The following is a description of a gene set: studied in species Mus musculus Genes predicted to be targets of miRBase v22 microRNA mmu_miR_497b in miRDB v6.0 with MirTarget v4 prediction scores > 80 (high confidence targets). Mouse Gene Set: MIR_497B from publication Chen Y, Wang X (PMID 31504780), and this is the list of marker genes: Sobp, Pld5, Sucla2, Fndc5, Pramel30, Olig3, Tmem68 (NCBI Gene Id 99971), Ubqln2, Ythdf1, Iqschfp, Ugt2b35, Sh3pxd2b, Kif5c, Ap1g1, Psen1, Mecp2, Dip2c, Gpr149, D5Ertd579e, Slc5a3, Nr1d2, Tmem158, Ldaf1, Eda2r, Kat7, Wdfy1, Tm9sf4, Btg1, Suco, Ccdc160, Zfp967, Relch, Lypla1, Adam10, Pdpk1, Tgfb3, Zfp970, Ndst1 (NCBI Gene Id 74141), Rasip1, Tle4, Stx3, Gprin3, P2ry1, Pfkfb3, Arl4c, Otud7b, Arhgef7, Plxna1, Dnm1, Acnat1, Ppp2r5c, Cry1, Bsn, Zfp781b, 2210418O10Rik, Stag2, Atxn7l3b, Rbfox2, Naa50, Lgalsl, Wdr5, Atf2, Frg1, Nfat5 (NCBI Gene Id 54446), Tra2a, Zc3h6, Atl2, Arhgap17, Rc3h1, Ino80d, Zc3h7b, Crebzf, Ankrd28, S100a3, Pcdh8, Slain2 (NCBI Gene Id 75991), Pik3r3, Pramel14, Kctd11, Sva, Sub1, Rictor, Gm6710 (NCBI Gene Id 627905), Notch2, Gm14325, Jchain, Skil, Glrp1, Zfp966, Slc12a6, D3Ertd751e, Kmt5b, Ppargc1a, Cldn1, Txlng, Acvr2b, Serpinb6c, Erich4, Zfp1009, Rbm7, Git1, Nono, Cntn6, Pcdh17, Arl6ip5, Sirt1, Cdyl2, Cers6, Hoxb5, Peak1, Zfp131